The following is a description of a gene set: Mouse Gene Set: TABULA_MURIS_SENIS_BROWN_ADIPOSE_TISSUE_MYELOID_CELL_AGEING from publication Tabula Muris Consortium (PMID 32669714) species: Mus musculus, and this is the list of marker genes: Smg1, Bsg, Tpm1, Egr1, Zc3h15, Stt3b, Tcp1, Tcf7l2, Rtf1, Il21r, Ptp4a3, Pkig, Abhd12, Id3, Plekhb2, Slc25a4, Mtdh, Prkcb, Dpt, P2ry12, Prrc2a, C1qb, Cd74, Gpx3, Tgfbr1, Dusp5 (NCBI Gene Id 240672), Zfp36l1, Fbln1, Dock2, Gnb1, Sparc, Trim28, Krt15, Ly6a, Atp1a1, Cx3cr1, Serbp1, Irf2, H2-Q6, Plp1, Mdh1, Klf2, Erbin, Zfp869, Zfp703, Eif4g3, H2-Ab1, Klc1, Mier1, Calm3, Stk24, Dcn, Apoe, Atp13a3, Sik1, Dpysl2, Atp5f1b, Limd2, Arrb2, Rnf10, Slc43a3, Cul1, Rpl13, Errfi1, Ubr4, Runx1, Polr2a, Serping1, Rnaset2b, Clic4, Hexb, Rara, Rock2, Ptms (parathymosin), Map3k14, Arhgef1, Rpl34, Cd274, Gns, Fus, Arl5c, Lrrc58, Hnrnpa0, Rel, Ppm1g, Bri3, Furin, Ago2, Nfic, Selenow, C1qc, Cebpd, Sf1, Ugdh, Celf1, Atxn2l, Eno3, Atp2a3, Atp5f1a, Cyfip1, Kdelr1, Drap1, Npepps, Serinc3, Tubb5, Gm6377, Ptprj, Qki, Leng8, Pmaip1, Vapb (NCBI Gene Id 99089), Mbp, Gsn (NCBI Gene Id 227753), Tmem119, Gnb2, Calm2, Tmem160, Rpl13a, Cxcl2, Pebp1, Thrap3, Hps4, Vamp4, Eno1b, Apbb1ip, Ndfip1, Ran, Gpr34, Ccdc80, Ckb, Zfand3, H2-Eb1, Sparcl1, Ppp1r18, Nfkbid, Zbtb7b (zinc finger and BTB domain containing 7B), Cd36, Gpr132, C1qa, Fmnl1, Stxbp3, Jun, Hsp90ab1, Foxp1, Ace, Sdc4, Ankrd13a, Ptpa, Arhgap17, Tuba1b, Tm9sf3, Map3k5, Map3k1, Dnajc13, E2f2, Ifnar1, Birc6, Chd4, Ppp4r3a, Ugp2, Ptma, Nfkbiz, H2-Aa, Lars2, Ywhae, Rab5c (RAB5C, member RAS oncogene family), Sgpl1, Jund, Gpx4, Bbc3 (NCBI Gene Id 170770), Ccdc50 (NCBI Gene Id 70600), Ppig, Dpep1, Gnas, Csf1r, Ins2, B3gnt2, Shkbp1, Tuba1a, Gspt1, Pou2f2, Trf, Kpna4, Zfp36, Lmo4, Selenop, Eef1a1, Kdm6b, Cd81, Ticam2 (NCBI Gene Id 225471), 9930111J21Rik1, Ctnnb1, Asph, Crip2, Lyz1, Cfl1, Traf1, Rhob, Vasp, Socs3, Cst3, Tnf, Oxct1, Tle5, Tmsb10, Olfml3 (NCBI Gene Id 99921), Ier2, Gak, Irf2bp2, Lypla1, Lgmn, Snrpc (U1 small nuclear ribonucleoprotein C), Pigt, Csf2ra, Gpsm3, Srrm2, Ep400, Abi3, Tob2, Myo1c, Dok1, Midn, Cxcr4, Crlf2, Pgp, Cavin1, Sf3b2, Fcho2